Given this list of marker genes B3gnt4, B3gnt2, B3gnt5 (UDP-GlcNAc:betaGal beta-1,3-N-acetylglucosaminyltransferase 5), B3gnt3, B4gat1, here is a description of the gene set: studied in species Mus musculus Mouse Gene Set: GOMF_N_ACETYLLACTOSAMINIDE_BETA_1_3_N_ACETYLGLUCOSAMINYLTRANSFERASE_ACTIVITY Catalysis of the reaction: a beta-D-galactosyl-(1->4)-N-acetyl-beta-D-glucosaminyl derivative + UDP-N-acetyl-alpha-D-glucosamine = an N-acetyl-beta-D-glucosaminyl-(1->3)-beta-D-galactosyl-(1->4)-N-acetyl-beta-D-glucosaminyl derivative + H+ + UDP.